The following is a description of a gene set: Genes predicted to be targets of miRBase v22 microRNA mmu_miR_3074_2_3p in miRDB v6.0 with MirTarget v4 prediction scores > 80 (high confidence targets). Mouse Gene Set: MIR_3074_2_3P species: Mus musculus from publication Chen Y, Wang X (PMID 31504780), and this is the list of marker genes: Lrrtm1, Col22a1, Six4, Spag16, Marcksl1, Rnf112, Dus2, Rpf1, Cd40lg, Dmwd, Ang6, Fut9, Drg1, Camsap2, Pdzk1ip1, Col12a1, Pgm3, Ddx5, Usp15, Pitx2, Vcf1, Slc12a1, Slc26a1, Cul4a, Skil, Slc22a12, Coro2b, Ak4, Cp, H2-M2, Rnft1, Nexmif, Ino80c, Morn3, Clcn3, Rab5b, Dach2, Tyrp1 (NCBI Gene Id 22178), Pclo, Vamp3, Ywhae, Slitrk3, Mllt10, Sorbs2, Serpinb13, Nsd3, Cbln1, Riok1, Ankle2, Ints8, Ets1, Ttpal, D3Ertd751e, Ptrh2, Fam241a, Mavs, Nkiras1, Megf11, Srsf10, Gnaq, Golt1a, Slc5a8, Qser1, Vxn, Adamts5, Snx27, Dnajb11, Crybg3, Chuk, Mak16, Zfp62, Slc7a14, Fas, Nfkbiz, Dennd5a, Map4k3, Lnpk, Thsd7a, Rb1, Krt12, Dedd, Bmpr2, Mfsd11, Col17a1, Mtcp1, Abca9, Plpp3, Prkaa2, Rbms3, Ndufa4, Slc8a1, Rnf150, Ezh2, Angptl4, Wif1, Cfap69, Nrg3 (NCBI Gene Id 18183), Alyref, Car8, Cyp2c50, Naip6, Ccdc157, Sprr2a2, Ssr1, Gpr174, Sprr2a1 (NCBI Gene Id 20755), Dennd4a, Cplx4, Wac, Mucl2, Tmem87a, Mon1b, Kras, Cpxcr1, Vax1, Eloc, Blmh (NCBI Gene Id 23826), Crebzf, Matr3, Zpbp2, Fig4, Pou3f4, Ifih1, Kpna4, Ttc27, Trip12, Nos1, Rgs5, Kcnj1, Gsdma2, Fbxw26, Tgfbr3, Btbd8, Atg3, Terb2, Klhl7 (NCBI Gene Id 67907), Cnot8, Trps1, Alyref2, Dusp8, Rnase10, Adamts19, Tmem41b, Zfp26, Nwd2 (NACHT and WD repeat domain containing 2), Npas3, Nepro, Pcdh17, Fign, Klra1 (killer cell lectin-like receptor, subfamily A, member 1), Tfdp1, BC004004, Ccser1, Ccdc88a, Fam210b, Gria4, Dhfr (dihydrofolate reductase), Mtfr1, Lrrc8c, Gpr155, Kcnj5, Galnt2, Mfap1a, Rc3h1, Mex3c, Or7d10